Given this list of marker genes Jak3, B2m, Gp1ba, Ccr7, Socs5, Il6ra, Zmiz1, Skint1, Cd276, Tjp1, Ihh, Kat5, Ambra1 (NCBI Gene Id 99255), Lgals8, Myo10, Cd5, Sox2, Il4i1, Emilin1, Dennd6a, Ripk2, H2-Oa, Pdcd1lg2, Kitl, Il12a, Wnt3a, Dpp4, Tgfbr2, Cyrib, Ptafr (platelet-activating factor receptor), Brd7, Ptpru, Emilin2, Nckap1l, Plpp3, H2-M3, Flot2, Il4ra, Cyld, Shb, Rasal3, Gli3, Afdn, Capn1, Gimap3, Tnfsf9, Actb, Vtcn1, Cd44 (CD44 antigen), Aif1, Bad, Brd2, Nck1, Rnase10, Dusp10, Hsph1 (NCBI Gene Id 15505), Dnaja3, Efnb2, Pawr, Ank3, Il23a, Abl2, Il1b, Ephb4, Smarcc1, Ap3d1, Pck1, Itga6, Vnn1, Fbxo38, Il2rg, Cd59b, Cd244a, Prkaa1, Jak2, Il21, Foxp3, Bcl6, St3gal4, Fut7, Ctsg (cathepsin G), Flot1 (NCBI Gene Id 14251), Havcr2, Xcl1, Selp, Tbx18, Cd81, Cd274 (NCBI Gene Id 60533), Lilrb4b, Il15 (interleukin 15), Piezo1, Cd1d2, Adam8, Il6st, Carmil2, Plaur, Ppp3ca, Chst4, Sirpa, Skap1 (NCBI Gene Id 78473), Mir326, Irf1, Nfkbiz, Socs1, Rela, Il7, Podxl, Tyk2, Cd86, H2-DMb1, Tnf, Traf6, Fcho1, Zp3, Nkap, Ccr5, Sox12, Cd74, Bmp7, Cd83, Wnt5a, Ptpn22, Sart1, Pkp3, Arid1a, Tfrc, Efnb3, Zap70, Phf10, Mdk, Cav1, H2-Eb1, Fgb, Epo, Elane, L1cam, Smarca2, Malt1, Pycard, Il36b, Smad7, Smarcd1, Smarcc2, Hlx, Btn2a2, Rag1, Vsir, Runx3, Thy1, Ceacam2, Ephb6 (NCBI Gene Id 13848), Sox13, Cd46, Anxa1, H2-Ob (NCBI Gene Id 15002), Sele, Tnfsf11, Ptprc, Il4, Smarcb1, Ccl21a, H2-Eb2, Arid2, Rap1gap, F11r, Lgals9, Megf10, Magi1, Tnfsf13b, Cd55, Pdpn, Cd80, Cd59a, Ccl2, Dock8, H2-DMa, Cd27 (CD27 antigen), Itgb2, Ep300, Cd209e, Selenok, Ywhag, Nfkbid, Ager, Nr5a2, Cd6, Il2ra, Lck, Alox5, H2-Ea, Ccr2, H2-Ab1, Blm, Nodal, Tnfsf14, Cxcl13, Vav1, Zfp609 (NCBI Gene Id 214812), Wnt10b, Sox4, Mfsd2b, Tgfb1, Prkcq, Hmgb1, Gpam, Cd209c, Mmrn1, Abl1, Bmi1, Klhl22, Smarcd2, Gimap5, Rps3, Slamf1, Vcam1, Slc7a1, Cd160, Rara, Il2, Alox15, Kifap3, Mex3b, Runx1, Slc4a1, Shh, Adk, Egr3, Opa1, Nlrp3, Prkcz, Fgg, Lgals1, Il12rb1, Il12b, Ap3b1, Nr4a3, Tnfsf4, H2-Aa, Nck2, Xbp1, Lef1, Irgm1, Hspd1, Card11, Cd55b, Cd3e, Hsp90aa1, Foxo3, Stat5a, Gcnt1, Rhoh, Itga4 (integrin alpha 4), Lep, Zbtb7b, Bcl10 (B cell leukemia/lymphoma 10), Coro1a, Cited2, Ccdc88b, Rhoa, Ada, Cd4, Smarca4, Pbrm1, Brd4, Rasgrp1, Il1rl2, Pkp1, Icam1, Fstl3 (follistatin-like 3), Cbfb, Tnfrsf13c, Igfbp2, Htr2a, Cd28, Il6, Stat5b, Sash3, Itpkb, Il1a, Il7r, Icos, Ccl5, Pnp, Fut4, Itgal, Cd40lg, Il18, Il3, H2-DMb2, Syk, Zbtb1, Ccl19, Gata3, Smarce1, Ptpn23, Icosl, Lilrb4a, Tespa1, Actl6b, Actl6a, Cd1d1, Dhps, Fadd, Spta1, Cd47, Efnb1, Jak1, Cd209d, Adam19, Pde4d, Has2, Btnl2, Igf2, Ifng, Irak1, Tnfrsf14, H2-T23, Cx3cl1 (C-X3-C motif chemokine ligand 1), Hes1, Cd24a, Igf1, Gcnt2, Chst2, Klhl25, Nfat5, Spn, Smarcd3, Ets1, Pik3r6, Kif26b, Ceacam1, Fga, Cdh1, here is a description of the gene set: species: Mus musculus Any process that activates or increases the rate or extent of cell adhesion to another cell. Mouse Gene Set: GOBP_POSITIVE_REGULATION_OF_CELL_CELL_ADHESION